The following is a description of a gene set: studied in species Homo sapiens Any process that modulates the frequency, rate or extent of the chemical reactions and pathways involving hydrogen peroxide. Human Gene Set: GOBP_REGULATION_OF_HYDROGEN_PEROXIDE_METABOLIC_PROCESS, and this is the list of marker genes: HDAC6, NOXA1, NNT, PRDX2, DUOXA2, RAC1, SNCA, RAC2, ZNF205, MT3, MPV17L, SOD2, HP, PINK1, STAT3, NOXO1, DUOXA1, FYN